Given this list of marker genes C2CD5, LONP2, PEX6, HSPA5, TRAM2, SEC62, SEC61A2, SEC61G, PEX7, GLP1R, SEC61B, PEX2, SEC61A1, PEX1, PEX16, SEC63, TRAM1, USP9X, PEX5, TRIM37, PEX12, TRAM1L1 (translocation associated membrane protein 1 like 1), PEX10, PEX5L, SRP54, PEX14 (NCBI Gene Id 5195), PEX13, PEX26, ZFAND2B, BCR, RTN2, here is a description of the gene set: studied in species Homo sapiens The directed movement of proteins in a cell, from one side of a membrane to another by means of some agent such as a transporter or pore. Human Gene Set: GOBP_INTRACELLULAR_PROTEIN_TRANSMEMBRANE_TRANSPORT